Given this list of marker genes APC, SPTBN2, FGF13, CAPZA2, TWF2, CCDC88C, TWF1, TRPV4, SPTAN1, TMOD1, LMOD3, SVIL, GAS2L2, DMTN, VILL, TRIOBP, SCIN, CAPZA3, FLII, MAP1A, SPEF1, AURKB, TMOD2, CKAP2, CLASP2, SPECC1L, PIK3CA, SPTBN5, WDR47, MAP1B, BBOF1, TAOK1, CARMIL2, MID1IP1, PDXP, ADD3, EPS8, BMERB1, LIMA1, NES, SWAP70, WDR1, CAPZA1, DIAPH3, LMOD1, CLASP1, ADD2, APC2, SPTBN4, GAS2L1, MAP6D1, SPTBN1, NAV3, TRIM54, MAP1S (NCBI Gene Id 55201), PLEKHH2 (pleckstrin homology, MyTH4 and FERM domain containing H2), CFL2, KATNB1, CIB1, MTPN (NCBI Gene Id 94351), MID1, PLEK, CAPZB, SEMA5A, KIF21A, ASB2, LMOD2, HDAC6, SPAST, SPTB, AVIL, STMN2, ADD1, SPTA1, SLN, F2RL1, ASPH, CFL1, TMOD3, VIL1, TPX2, ATXN7, HDGFL3, CAPG, TMOD4, SH3BP1, ARHGEF2, CARMIL1, ACTN2, DSTN, TTBK2, CAMSAP2, RDX, CRACD, GSN, WASHC2C, here is a description of the gene set: species: Homo sapiens Any process that modulates the frequency, rate or extent of protein depolymerization. Human Gene Set: GOBP_REGULATION_OF_PROTEIN_DEPOLYMERIZATION